The following is a description of a gene set: species: Homo sapiens Human Gene Set: GOBP_REGULATION_OF_ADENYLATE_CYCLASE_ACTIVATING_G_PROTEIN_COUPLED_RECEPTOR_SIGNALING_PATHWAY Any process that modulates the frequency, rate or extent of an adenylate cyclase-activating G protein-coupled receptor signaling pathway., and this is the list of marker genes: PDE4A, PDE4D, PDE4B, GSK3A, PDE10A (phosphodiesterase 10A), PRKCA, RACK1, ATP2B4, POMC, PDE3A, MRAP, NOS1, PDE3B, MGRN1, PDE2A, GNAI2, APLP1, CRTC3, ARRDC3, MRAP2